The following is a description of a gene set: A single cancer cell contains large numbers of genetic alterations that in combination create the malignant phenotype. However, whether amplified and mutated genes form functional and physical interaction networks that could explain the selection for cells with combined alterations is unknown. To investigate this issue, we characterized copy number alterations in 191 breast tumors using dense single nucleotide polymorphism arrays and identified genes with copy number gain organized into 30 amplicons. Amplicons were distributed unequally throughout the genome. Each amplicon had distinct enrichment pattern in pathways, networks, and molecular functions, but genes within individual amplicons did not form coherent functional units. Genes in amplicons included all major tumorigenic pathways and were highly enriched in breast cancer-causative genes. In contrast, genes with somatic mutations in breast cancer were distributed randomly over the genome, did not represent a functionally cohesive gene set, and were relatively less enriched in breast cancer marker genes. Mutated and gained genes did not show statistically significant overlap but were highly synergistic in populating key tumorigenic pathways including transforming growth factor beta, WNT, fibroblast growth factor, and PIP3 signaling. In general, mutated genes were more frequently upstream of gained genes in transcription regulation signaling than vice versa, suggesting that mutated genes are mainly regulators, whereas gained genes are mostly regulated. ESR1 was the major transcription factor regulating amplified but not mutated genes. Our results support the hypothesis that multiple genetic events, including copy number gains and somatic mutations, are necessary for establishing the malignant cell phenotype. Genes within amplicon 12q13-q21 identified in a copy number alterations study of 191 breast tumor samples. studied in species Homo sapiens Human Gene Set: NIKOLSKY_BREAST_CANCER_12Q13_Q21_AMPLICON from publication Nikolsky Y, Sviridov E, Yao J, Dosymbekov D, Ustyansky V, Kaznacheev V, Dezso Z, Mulvey L, Macconaill LE, Winckler W, Serebryiskaya T, Nikolskaya T, Polyak K (PMID 19010930), and this is the list of marker genes: EEF1AKMT3, MARCHF9, ZFC3H1, TSPAN8, RAB3IP, SLC35E3, CTDSP2, FRS2, DYRK2, OS9, CPSF6, RAP1BL, AGAP2, YEATS4, LYZ, XPOT, MDM2, GNS, THAP2, IL22, BEST3, KCNMB4, LRRC10, CNOT2, RAP1B, RASSF3, TMEM19, PTPRR, METTL1 (methyltransferase 1, tRNA methylguanosine), TSPAN31, MDM1 (NCBI Gene Id 56890), NUP107, IL26, CYP27B1 (NCBI Gene Id 5135), C12orf56, LGR5, CPM (carboxypeptidase M), CCT2, AVIL, CDK4, IFNG, CAND1, KICS2, TSFM, PTPRB, TBK1